Given this list of marker genes CAV2, CRIPTO, SNX9, CYP4V2 (cytochrome P450 family 4 subfamily V member 2), CYFIP1, FBXW7, RNF19B, PGLYRP1, CDIPT, DERL1, AVEN, CREB3L2, CASP4, RAPGEF5 (NCBI Gene Id 9771), IGF1R, INPP4B (NCBI Gene Id 8821), IL18R1, TESC, FAM210B, SH3BP5, PHYKPL, ILDR1, NUDT22, ABCB1, ALDOC, TXNIP, GPR18, CCDC126, GPRIN3, RNH1, SNX20, GALM, TRAF5, IRF2BPL, EIF5A2, XPO4, TMPRSS2, NUMB, SELENOM, SLC7A10, ALCAM, HOXD11, RNASE4, RUNDC3B, DENND5A, ELL2, TRAF3IP2, MFAP1, NIBAN1, P2RY14 (purinergic receptor P2Y14), TM7SF3, FBXO21, DNASE1L3, CRTC3, LCLAT1, ACOT2, RNF128, ECH1, IL1R2, NPC2, LATS2, POGLUT3, ITGAE, S1PR4, RFLNB, CEMIP2, TENT5C, ARMC7, SMTN, TIAM1, CAPG, SLAMF6, RRAGD, RIPK2, BIN3 (bridging integrator 3), CRIP1, IL6R, SNX31, P2RY10, ESM1, CDC42SE2, CNKSR3, NCF4, ADAM9, KLK8, METTL18 (NCBI Gene Id 92342), SEMA4F, CEBPB, MFNG, FECH, TOR4A, ABCC4, HLA-DMA, RNF216, ALAD, TUBG2, BATF, ABLIM2, BFSP2 (beaded filament structural protein 2), ACSBG1, SGPL1, MARVELD1, RRP1B, CCR6, TAF9B, BCL9L, TMIE, DIAPH2, DONSON, GPX7, SYNGR2, MUL1, KCNK6, NUCB2, KLRG1, CCDC22, NFIL3, CLN6 (CLN6 transmembrane ER protein), STING1, ACBD7, PADI1, FAM81A, NRN1, PKP3, MID1IP1 (MID1 interacting protein 1), MDFIC, TENT5A, ZNF23, PROS1, AXL, BCL7C, HOPX, CMTM7, ATXN1, SDCBP2, SQOR, ZCCHC3, C19orf12, JDP2, SPSB1, CRYL1, ANTXR2, NFKBIL1, UBXN2B, FCRL1, S100A11, PSME2, C9orf85, AKR1E2, DNAJB2, VSIG10, PDE8A, MAF, ARRDC4, SAPCD1, LRRN4, GLUD1, ACOT8, PRG4, DGAT2, UNC119B, EEF1AKMT1, CERS4, FHIP1A, SUSD3, MYO3B, MLX, VPS28, CHST12, GPR34, CALHM2, ECI1, GPR155, MYNN, GOLM1, FXYD5, TBC1D30, VAMP8, NAPRT, ALDH2, C16orf54, PSMB9, RUNX3, TMEM185A, GPR15, MPHOSPH6, GM2A, PLPP1, SMARCD3, RBM11, LPXN, SYT11, FRMD8, ARSB, PPCS, DIP2A, ZSCAN12, GRIK5, MTHFD2, CDC42EP3, here is a description of the gene set: species: Homo sapiens The transcription factor FoxP3 partakes dominantly in the specification and function of FoxP3+ CD4+ T regulatory cells (Tregs), but is neither strictly necessary nor sufficient to determine the characteristic Treg transcriptional signature. Computational network inference and experimental testing assessed the contribution of several other transcription factors (TFs). Enforced expression of Helios or Xbp1 elicited specific signatures, but Eos, Irf4, Satb1, Lef1 and Gata1 elicited exactly the same outcome, synergizing with FoxP3 to activate most of the Treg signature, including key TFs, and enhancing FoxP3 occupancy at its genomic targets. Conversely, the Treg signature was robust to inactivation of any single cofactor. A redundant genetic switch thus locks-in the Treg phenotype, a model which accounts for several aspects of Treg physiology, differentiation and stability. Genes up-regulated in CD4 T conv over-expressing: FOXP3 versus IRF4 and FOXP3. from publication Fu W, Ergun A, Lu T, Hill JA, Haxhinasto S, Fassett MS, Gazit R, Adoro S, Glimcher L, Chan S, Kastner P, Rossi D, Collins JJ, Mathis D, Benoist C (PMID 22961053) Human Gene Set: GSE40274_FOXP3_VS_FOXP3_AND_IRF4_TRANSDUCED_ACTIVATED_CD4_TCELL_UP